Given this list of marker genes Irs1, Tgfbr3, Gas1 (NCBI Gene Id 14451), Sord, Scara3, Ddit4l, Syt11, Klhl24, Bub1, Vegfd, Vcam1, Lilrb4b, Cd36, Oasl2, Runx1t1, Ifit1, Gamt (guanidinoacetate methyltransferase), Pdk4, Prss35, G6pd2, Kitl, Cdh2 (cadherin 2), Gulp1, Cyp1b1, D17H6S56E-5, Sh3bp5, Ogn, Lpar4, Sema3a, Ctnnal1, Glrx, Rarb, Cdc42ep2, Adhfe1, Nusap1, S1pr3, Svil, Usp18, Mmp11, Ampd3, Mpped2, Plekhh2, Aqp1, Herc6, Hoxc10, Pten, Cd24a, Slc24a3, Igf1, Nmi, Cenpj, Thbd, Med12l, Fat4, Zwilch, Rnasel, Pmp22, Fmnl2, Ptprd, Auts2, Bnip3l, Nr1d2, Ptx3, Serhl, Mt1, Reps2, Pik3r3, Rfc4, Zfp608, Zfp28, Tgtp1, AW551984, Tox, Cyp7b1, Plcb1, Marcks, Wdr19, Lum, Lama4, Mmp16, Sesn3, Zfp521, Ccl12, Stmn1, Plek, Hmmr, Lifr, Mest, Clip4, Lrrn3, Lgr4 (NCBI Gene Id 83944), Rab30, Tle6, Knstrn, Serpinb1a, Foxp2, Rfc3, Acss2, Map2, Trim37, Pik3r1, Ddc, Pwwp3b, Cand2, Meis2, Arl6ip1, Pde1a, Adgrg2, Tmem86a, Il1rn, Peg3, Adgrg6, Pira1 (paired-Ig-like receptor A1), Prkar2b, Mki67, Tspyl3, Rasgrp3, Ebf3, Dclk1, Sh3bgrl, Adamts1, Rspo3 (NCBI Gene Id 72780), Zic1, Slc14a1, Mterf2, Sim2, Tmem53, Casp12, Ldb2, Ifit3, Lrrcc1, Tk1, Pdp1, Pdgfra, Mef2c, Plpp3, Sbk1, Tcea3, Dtl, Gas2, Ppp1r3c, Slc12a2, C3ar1, Nqo1, Dbp, Msh6, Ednrb, Adm, Osr1, Rtl3, Pdlim2, Sorbs2, Rcbtb2, Elovl6, Idh1, Cenpk, Dab2, Six1, Cpa6, Arhgap18, Agtr2, Cavin2, Trim2, Lmo7, Diras2, Evi2a, Hacd4, Sesn1, Cdkn3, Slc16a4, Per3, Nuf2, Plscr2, Epha7, Ablim1 (NCBI Gene Id 72478), Adamts5, Shox2, Irgm2, Palmd (NCBI Gene Id 66688), Ccl9, Fgf7, Mastl, Prickle2, Stmn2, Il6st, Serpinb6b, Mgst1, Mrc1, Arhgap28, Eya4, Fbxl7, Prrx1, Itgb3bp, Angpt2 (NCBI Gene Id 11601), Pcdh7, Trps1, Stat1, Celf2, Gstm2, Npr3, Arnt2, Eif2ak2, Pde5a, Ccnb1, Serpinb9, Arhgap20, Arid5b, Slc40a1, Dzip1, Nfix, Parp9, Iigp1, Arrdc3, Il18, Tcf7l2, Igfbp5 (insulin-like growth factor binding protein 5), Fignl1, Man1a, Kcnd2, Phip, Dhrs3, Mllt3, Zfhx4, Nfia, Scara5, Unc5c, Plekhg1, Dixdc1, Pcdh9, Gbp2 (NCBI Gene Id 14469), Cnksr3, Tmt1a, Nfib (nuclear factor I/B), Lpl (lipoprotein lipase), Mrgprf, Cbx6, Rnd3, Zfp467, Prim1, Pbx1, Acadm, Thsd7a, Ephx1, Tshz1, Mbnl3, Eya1, Rtp4, Rspo2, Zfand1, Ifit2, Fgfr2, Calhm5, Tceal1, Malat1, Foxc1, Smarca2, Cd93, Trim21, here is a description of the gene set: species: Mus musculus Transforming growth factor beta (TGF-beta) and platelet-derived growth factor A (PDGFAlpha) play a central role in tissue morphogenesis and repair, but their interplay remain poorly understood. The nuclear factor I C (NFI-C) transcription factor has been implicated in TGF-beta signaling, extracellular matrix deposition, and skin appendage pathologies, but a potential role in skin morphogenesis or healing had not been assessed. To evaluate this possibility, we performed a global gene expression analysis in NFI-C(-/-) and wild-type embryonic primary murine fibroblasts. This indicated that NFI-C acts mostly to repress gene expression in response to TGF-beta1. Misregulated genes were prominently overrepresented by regulators of connective tissue inflammation and repair. In vivo skin healing revealed a faster inflammatory stage and wound closure in NFI-C(-/-) mice. Expression of PDGFA and PDGF-receptor alpha were increased in wounds of NFI-C(-/-) mice, explaining the early recruitment of macrophages and fibroblasts. Differentiation of fibroblasts to contractile myofibroblasts was also elevated, providing a rationale for faster wound closure. Taken together with the role of TGF-beta in myofibroblast differentiation, our results imply a central role of NFI-C in the interplay of the two signaling pathways and in regulation of the progression of tissue regeneration. Genes down-regulated in MEF cells (embryonic fibroblast) upon stimulation with TGFB1 for 10 h. from publication Plasari G, Calabrese A, Dusserre Y, Gronostajski RM, McNair A, Michalik L, Mermod N (PMID 19752192) Mouse Gene Set: PLASARI_TGFB1_TARGETS_10HR_DN